The following is a description of a gene set: from publication Cui A, Huang T, Li S, Ma A, Pérez JL, Sander C, Keskin DB, Wu CJ, Fraenkel E, Hacohen N (PMID 38057668) species: Mus musculus Cytokines mediate cell-cell communication in the immune system and represent important therapeutic targets. A myriad of studies have highlighted their central role in immune function, yet we lack a global view of the cellular responses of each immune cell type to each cytokine. To address this gap, the authors created the Immune Dictionary, a compendium of single-cell transcriptomic profiles of more than 17 immune cell types in response to each of 86 cytokines (>1,400 cytokine-cell type combinations) in mouse lymph nodes in vivo. A cytokine-centric view of the dictionary revealed that most cytokines induce highly cell-type-specific responses. For example, the inflammatory cytokine interleukin-1β induces distinct gene programmes in almost every cell type. A cell-type-centric view of the dictionary identified more than 66 cytokine-driven cellular polarization states across immune cell types, including previously uncharacterized states such as an interleukin-18-induced polyfunctional natural killer cell state. Genes positively differentially expressed in cell type: B cell upon treatment with cytokine: IL-12 in mouse lymph nodes in vivo. Mouse Gene Set: CUI_B_CELL_IL12_RESPONSE_UP, and this is the list of marker genes: Psmd7, Emid1, Stat1, Rrp9, Cks2, Hsh2d, Ifi47, Stat2, Tgs1, Gbp5, Igtp, Spcs2, Ly6a, Hadhb, Irf9, Irgm1, Serpina3g, Manf, Rbm18, Parp9, Socs1, Phf11b, Psmb9, Nufip2, Nlrc5, Irf1